The following is a description of a gene set: Mouse Gene Set: GERHOLD_RESPONSE_TO_TZD_UP from publication Gerhold DL, Liu F, Jiang G, Li Z, Xu J, Lu M, Sachs JR, Bagchi A, Fridman A, Holder DJ, Doebber TW, Berger J, Elbrecht A, Moller DE, Zhang BB (PMID 12021175) Genes up-regulated in 3T3-L1 cells (fibroblast) induced to differentiate to mature adipocytes and then treated with a TZD derivative AD-5075, a PPARG activator. species: Mus musculus PPAR gamma is an adipocyte-specific nuclear hormone receptor. Agonists of PPAR gamma, such as thiazolidinediones (TZDs), promote adipocyte differentiation and have insulin-sensitizing effects in animals and diabetic patients. Affymetrix oligonucleotide arrays representing genes were employed to profile the gene expression responses of mature 3T3-L1 adipocytes and differentiating preadipocytes to a TZD PPAR gamma agonist in vitro. The expression of genes was significantly up- or down-regulated by more than 1.5-fold during differentiation and/or by treatment with TZD, and these genes were organized into 32 clusters that demonstrated concerted changes in expression of genes controlling cell growth or lipid metabolism. Quantitative PCR was employed to further characterize gene expression and led to the identification of beta-catenin as a new PPAR gamma target gene. Both mRNA and protein levels for beta-catenin were down-regulated in 3T3-L1 adipocytes compared with fibroblasts and were further decreased by treatment of adipocytes with PPAR gamma agonists. Treatment of db/db mice with a PPAR gamma agonist also resulted in reduction of beta-catenin mRNA levels in adipose tissue. These results suggest that beta-catenin plays an important role in the regulation of adipogenesis. Thus, the transcriptional patterns revealed in this study further the understanding of adipogenesis process and the function of PPAR gamma activation., and this is the list of marker genes: G0s2, Fabp4, Casp8, Ccnd2, Ccnd1, Hgfac